The following is a description of a gene set: Human Gene Set: ZNF547_TARGET_GENES studied in species Homo sapiens Genes containing one or more binding sites for (ZNF547) in their promoter regions (TSS -1000,+100 bp) as identified by GTRD version 20.06 ChIP-seq harmonization. from publication Yevshin I, Sharipov R, Kolmykov S, Kondrakhin Y, Kolpakov F (PMID 30445619), and this is the list of marker genes: TARS1-DT, TLE6, LMNA, PPIAP72, ING1, ZMPSTE24-DT, CPS1, TBC1D20, POLE4, GSTO1, NKAPP1, CEBPA-DT, CLNS1A, SDC4, RCAN2, RAMP1, ATP5PBP7, ZNF18, SOX21, STK17A, GGPS1, NECTIN3, C15orf48, PTGER2, MAF1, MT-TH, SPATA20, B4GALT7, BAHCC1, CDC37, PA2G4, VPS13B-DT, TSPAN10, PDE6D, CSTB, LINC01521, MORF4L2, VAMP8, TMEM248, LRRC17, IFT172 (intraflagellar transport 172), GFI1, TARS1, LIFR, PRKAR1A, ZSCAN31 (NCBI Gene Id 91921), EXOSC2, STIL (NCBI Gene Id 6491), ZNF749, TEF, ALG10B, B3GALT4, COG3, ZNF140, ANXA2R (NCBI Gene Id 389289), ANKRD28, PGBD5, DPY19L3 (NCBI Gene Id 147991), SLC17A3, FBN1-DT, CDCA2, FRA10AC1, NTSR1, PIK3IP1, USP6NL, MIR3678, CCL2, MPP1, TPT1, ZNF222-DT, PRRG1, ZBTB38, MIPOL1, RNU7-62P, FAM149A, INTS5, ZNF131 (NCBI Gene Id 7690), SLC38A4, MSL2, MIR4799, NEDD9, LAMP1, SLC13A4, SNUPN, JPH1, PCDHGA6, DLEU1, SLC28A2-AS1 (NCBI Gene Id 101928414), DTL (NCBI Gene Id 51514), TVP23B, ENO3, MT-TL2, N4BP2L2, NFE2L2, BCRP2, USP30, EP300, ZNF134, SLC30A1, SF3A3, WDR11, TENT4A, NDUFAF3, TRA2B, RELT, LINC01122 (NCBI Gene Id 101927285), MTMR12, CASKIN2, NOL6, NMT2, MARCHF6-DT, ADD3-AS1, RBFOX2 (NCBI Gene Id 23543), EIF3J, NEDD4L, PATZ1, ENSG00000232995, GNAL, ZNF35 (NCBI Gene Id 7584), H4C1, LINC02916, ZNF527, C18orf21P1, CELF2-AS2, INTS7, SMG7, HDAC2, SEPTIN9, ANO8, MDP1, NSL1, EXD3, ZNF222, SAP30, IFT46, MRPL44, MAP1S, TATDN3, MIR3650, ZNF879, KCNIP1-AS1, HINT1, SELENOV, WDFY1, ANK2, USPL1, HIBCH, CYREN (cell cycle regulator of NHEJ), RBM19, CCDC126, CDK4, MNT, THRA, GMNN, IRS1, HSPA14, CHST11, CTSD, GBA1, GTPBP2, ARMC3, PLCH1, GRB2, IGHMBP2, SPEG, DNPH1, DCBLD2, NUF2, BOLA1, TRAF3IP2, DDX18, RND1, MC3R, HMGB1, OR1X5P, RAD52, MTR, LINC02136 (long intergenic non-protein coding RNA 2136), SEMA6D, PIK3IP1-DT, ESRRA, SLC12A8, LAMTOR2, RNU7-90P, NEDD4, ACBD5, PDCD6P1, LINC03060, COQ2 (coenzyme Q2, polyprenyltransferase), FES (FES proto-oncogene, tyrosine kinase), TBX18, ADRA1D, CXXC1, HTR5A, KDM4B, USP40, MARCHF6, PDGFRB, KCTD9, MARCHF9, DIS3L, ZNF850, LINC01300, SHARPIN, TOR1AIP1, NOL4, RABGGTA (NCBI Gene Id 5875), ATP1A3, POP4, CEBPA, CTNNBL1, ENSG00000213963, ZNF609, VPS13B, OAT, TNFRSF10B, DRG2, LINC01232, RRN3P1, CREB5, MED24, MRPL21, ZNF224, LZTS2, CLDN23, TRIM15, SMG7-AS1, WWC2, CEBPG, OTULIN-DT, EIF3J-DT, RNF14, LINC00869, PHLDB1, CBX4, MT-TS2, NPLOC4, DOC2A, MTCO3P12, GTPBP3, QSER1, ANKRD10, MAN2C1, ENSG00000223834 (NCBI Gene Id 124906892), ESAM, MYO10, ZMPSTE24, USP54, DSTYK, C15orf39, SENP6, IL34, PCDH17, RHOA, ZFP14, EWSAT1 (NCBI Gene Id 283673), LYRM7, MAP7D2, STX12 (syntaxin 12), PACSIN2, TPT1-AS1, FOXB2 (NCBI Gene Id 442425), JPX, ENSG00000271860, ENSG00000267260, RPS7, PLA2G15, RNF38, LANCL1, ENSG00000245651 (novel transcript), CELF2-DT, KDM1A, GNG4, SSX2IP, SNHG30, ESAM-AS1, ZNF599, DALRD3, MRPS31, TCTA, TSSK3, SHISA3, C19orf47, POLR2J4, IFI35, PCSK2, LINC02458, CHN2, CLN8, S100A2, HOXC10, KLF6, SGK1, GRPEL1, KRT40, LINC00431, PCF11, NOXA1 (NCBI Gene Id 10811), TSHZ2, PLCE1, TMCC2, BAIAP2, SMIM10L2B, MTO1, GAPDHP22, AHNAK2 (NCBI Gene Id 730269), UBE2E3, ZNF233, MRPL3, MTRF1, VMP1, SP3, CDK20, RNU4ATAC16P, IFT56, SMIM5, STARD4, PKMP3, SETD5, OTULIN, SSBP2, WDR11-DT, SAP30-DT, VTA1, FBN1, WTAP, MTND5P11, RPL37 (ribosomal protein L37), BAZ2A, FAM157C, SPRTN, SRSF1, ARID4B, RGS5, MIR191 (NCBI Gene Id 406966), PNMA6E, HOXC-AS3, RBBP5, TMEM130, ZNF277, NECTIN3-AS1, TTC1 (tetratricopeptide repeat domain 1, NCBI Gene Id 7265), OR8S21P, RFX4, CDNF, UBQLN4, COPS7B, RAB40B, ONECUT1, FOSL2